Given this list of marker genes CLTCL1 (clathrin heavy chain like 1), VPS41, VPS33A, CLTC, SCN10A, CLTA, SCLT1, BAIAP2L2, here is a description of the gene set: Human Gene Set: GOCC_CLATHRIN_COMPLEX studied in species Homo sapiens A protein complex that consists of three clathrin heavy chains and three clathrin light chains, organized into a symmetrical three-legged structure called a triskelion. In clathrin-coated vesicles clathrin is the main component of the coat and forms a polymeric mechanical scaffold on the vesicle surface.